The following is a description of a gene set: studied in species Homo sapiens Human Gene Set: WP_OVERVIEW_OF_PROINFLAMMATORY_AND_PROFIBROTIC_MEDIATORS Overview of proinflammatory and profibrotic mediators, and this is the list of marker genes: CCL5, IL19, LIF, IL33, IFNA21, TGFB1, CXCL11, CCL27, IFNL1, IL26, MMP9, CXCL10, CCL15, CCL25, CCL19 (NCBI Gene Id 6363), MMP1, IL15, IL21, CCL3, XCL1, XCL2, CCL1, IL12B, IL1RN, IL4 (interleukin 4), CCL24, CXCL12, IL17F, IFNA8, IL17A, IFNA7, CCL16, CCL2, CCL22, IL1F10, IFNK, IFNB1, CCL21, NFKB1, CCL23, IL17C, CXCL13, IFNA2, IFNG, IL17D, CXCL17, AREG, CSF2, CSF3, IL2, IL36A, SPP1, CCL4L2, CXCL2, CXCL8, IFNA14, CCL28, CXCL16 (C-X-C motif chemokine ligand 16), TNFSF13, IL7, IL17B, IFNA6, IL10, MMP3, IL31, CCL14, TSLP, IL36G, IL37, OSM, PF4V1 (platelet factor 4 variant 1), CSF1, IFNW1, LTA, IFNA13, VEGFA, CCL7, IFNL2, CXCL6, CCL18, IFNA1, CXCL14, IL36RN, IL20 (interleukin 20), CXCL5, EPO, TNFSF13B, IL25, IFNA10, PPBP, CNTF, IL27, TNF, CCL3L3 (NCBI Gene Id 730422), CCL20 (C-C motif chemokine ligand 20), CXCL9, IL1B, IL22, IL36B, CCL4, IL13, IL23A, IL5, CCL8, IL24, CX3CL1, PF4, IFNA16, CCL17, IL11, IL6, IL3, CTF1, IFNL3, IFNA4, IL12A, IL9, CCL11, IFNA5, IFNA17, IL1A, IL18, CCL26, CXCL1, CXCL3, CCL13 (C-C motif chemokine ligand 13), EBI3